The following is a description of a gene set: Genes down-regulated in comparison of untreated CD8+ dendritic cells (DC) at 16 h versus those treated with IFNG at 16 h. from publication Orabona C, Puccetti P, Vacca C, Bicciato S, Luchini A, Fallarino F, Bianchi R, Velardi E, Perruccio K, Velardi A, Bronte V, Fioretti MC, Grohmann U (PMID 16339401) Although much is known on the transcriptional profiles of dendritic cells (DCs) during maturation, the molecular switches critical for the acquisition of a tolerogenic program by DCs are still obscure. In the present study, we explored the gene expression pattern of CD8+ DCs purified from the mouse spleen and treated with interferon (IFN)-gamma. The cytokine, indeed, potentiates the tolerogenic potential of this DC subset via induction of the immunosuppressive tryptophan catabolism mediated by indoleamine 2,3-dioxygenase (IDO). By comparing the expression of the IFN-gamma-modulated genes in IDO+ versus IDO- murine DCs, we found a consistent and selective association of the IDO-competent phenotype with the down-modulation of the Tyrobp gene, encoding the adapter molecule DAP12. IFN-gamma-mediated down-modulation of this gene involved IFN consensus sequence binding protein (ICSBP), a transcription factor also known as IRF-8. While silencing of Tyrobp conferred IDO functional competence on IDO- DCs, silencing of Icsbp1 in IDO+ cells completely abolished IDO expression and function. In parallel, silencing of TYROBP conferred IDO competence on human IDO- DCs while silencing of IRF8 impaired IDO expression and activity in human IDO+ DCs. Therefore, the same small set of molecular switches controls IDO competence in murine and human DCs. species: Homo sapiens Human Gene Set: GSE3337_CTRL_VS_16H_IFNG_IN_CD8POS_DC_DN, and this is the list of marker genes: MTTP, PFKFB3, ANKFY1, GGA1, CD37, TNFAIP2, MARS1, DAD1, PREP, LYSMD1, OSBPL5, SELENOH (NCBI Gene Id 53396), TFIP11, CAPNS1, UBE2L6, STX2, BST1, TRAF3IP2, RCC2, PSMB10, OXCT1, PSMD4, RNASEH2A, TOMM40 (NCBI Gene Id 10452), MAP3K4, ABHD8, POLA2, NUDT3, ABR, MNT, EGLN2, FASTKD5, ARPC5L, PAFAH1B3, CNN3 (NCBI Gene Id 1266), SEPTIN9, CXCL9, POU6F1, SMARCB1, NDUFV1, HLA-DOA, STIL, RAF1, ACOD1, SPARC, CISD1, KAT7, PPA1, ISG20, MAP4K1, SCAMP3, OGFR, CSNK2A2 (NCBI Gene Id 650690), LPP-AS2, FLT4, PSME1, NOC4L, NUP62, IRGM, PIM1, CMPK2, SLC9A8, BUD31, UBD, IL18BP, HCN1, CD19, ZEB1, PTK2B, CYFIP2, STXBP1, KL, CCL2 (C-C motif chemokine ligand 2), EIF1B, TAF1C, MICOS13, HDC, IRF1, CD180, SAMHD1, NRP1, DPP4, FLNB, CYBC1, CALCR, UPP1, SOCS1, PITPNB, TMEM160, VARS1, BCL7B, TANGO2, RNPS1, NAA40, KIF1B, LYPLA2, CXCR2, GPS1, TBL2, CDT1, GBP7, SIVA1, INPP5B, FDPS, HLA-DMA (major histocompatibility complex, class II, DM alpha), PSME2, SOD2, EMC10, NOTCH1, KANSL2, GBP2, WARS1, NELFE, IDNK, STX8, AARS1, BCKDK, TPST1, PKIB, RNF19B, HCLS1, ECE1 (NCBI Gene Id 1889), PLPP1, POLR2L, PQBP1, CAPN1, PML, HLA-DRB1, TRIM21, SF3B3, GNAT2, STAT3, PMF1, GRINA, GLIPR2, RAB5IF, PSMC3IP (PSMC3 interacting protein), CXCR3, CUEDC2, CD79A, TRIM27, WDHD1, TMEM41B, IGKC, SLCO3A1, RAD23B, AP1S1, PARD6A, AGPAT5, WDR55, CA3, NAMPT, SERTAD1, NAA38, BCL7C, HSD3B7, MRE11, COL5A2 (collagen type V alpha 2 chain), DVL1, CDC20, CDK2AP2, AK3, RAN, IL12RB1, IFT27, CPOX, TSPO, TAP2, C8orf33, DPM3, EXTL3, CCND3 (NCBI Gene Id 896), SMAGP, TAP1, FRMD8, POLDIP3, UBA7, DXO, FKBP8, FUS, MCM2, MFNG (NCBI Gene Id 4242), PDAP1, CHMP1B, LIN9, DAXX, FAM110A, IRF8, CASP9, MED28, UNC119, UHRF1, NUP85, HIP1R, ADRM1, BCL3, PLOD3, NFIX, MCM7, C3